Given this list of marker genes Sox9, Trim8, Cast, Ywhae, Tle1, Fap, Ptgr1, here is a description of the gene set: Early prostate development genes (down-regulated at 6 hr dihydrotestosterone) which are also down-regulated in high grade prostatic intraepithelial neoplasia (PIN) vs invasive cancer. from publication Schaeffer EM, Marchionni L, Huang Z, Simons B, Blackman A, Yu W, Parmigiani G, Berman DM (PMID 18794802) species: Mus musculus Mouse Gene Set: SCHAEFFER_PROSTATE_DEVELOPMENT_AND_CANCER_BOX2_DN Cancer cells differentiate along specific lineages that largely determine their clinical and biologic behavior. Distinct cancer phenotypes from different cells and organs likely result from unique gene expression repertoires established in the embryo and maintained after malignant transformation. We used comprehensive gene expression analysis to examine this concept in the prostate, an organ with a tractable developmental program and a high propensity for cancer. We focused on gene expression in the murine prostate rudiment at three time points during the first 48 h of exposure to androgen, which initiates proliferation and invasion of prostate epithelial buds into surrounding urogenital sinus mesenchyme. Here, we show that androgen exposure regulates genes previously implicated in prostate carcinogenesis comprising pathways for the phosphatase and tensin homolog (PTEN), fibroblast growth factor (FGF)/mitogen-activated protein kinase (MAPK), and Wnt signaling along with cellular programs regulating such 'hallmarks' of cancer as angiogenesis, apoptosis, migration and proliferation. We found statistically significant evidence for novel androgen-induced gene regulation events that establish and/or maintain prostate cell fate. These include modulation of gene expression through microRNAs, expression of specific transcription factors, and regulation of their predicted targets. By querying public gene expression databases from other tissues, we found that rather than generally characterizing androgen exposure or epithelial budding, the early prostate development program more closely resembles the program for human prostate cancer. Most importantly, early androgen-regulated genes and functional themes associated with prostate development were highly enriched in contrasts between increasingly lethal forms of prostate cancer, confirming a 'reactivation' of embryonic pathways for proliferation and invasion in prostate cancer progression. Among the genes with the most significant links to the development and cancer, we highlight coordinate induction of the transcription factor Sox9 and suppression of the proapoptotic phospholipid-binding protein Annexin A1 that link early prostate development to early prostate carcinogenesis. These results credential early prostate development as a reliable and valid model system for the investigation of genes and pathways that drive prostate cancer.